Given this list of marker genes IKZF5, ITGB3, GP1BB, GP6, GP9, GP1BA, ITGA2B, EPHB2, here is a description of the gene set: Impaired ristocetin-induced platelet aggregation Abnormal response to ristocetin as manifested by reduced or lacking aggregation of platelets upon addition of ristocetin. Human Gene Set: HP_IMPAIRED_RISTOCETIN_INDUCED_PLATELET_AGGREGATION species: Homo sapiens